The following is a description of a gene set: Human Gene Set: MIR6892_3P studied in species Homo sapiens Genes predicted to be targets of miRBase v22 microRNA hsa-miR-6892-3p in miRDB v6.0 with MirTarget v4 prediction scores > 80 (high confidence targets). from publication Chen Y, Wang X (PMID 31504780), and this is the list of marker genes: ARRDC3, TRAF6, BCO2, SRSF6, SKAP2, ZBTB20, SSTR3, SYCP2, EMX2, TNS1, PTDSS1, LIN28B, MAFB, MSI2, CHD3, SLC39A1, ANAPC13, TMT1B, LYZL1, SDC3, DDX6, ASTN1, GLI3, RASSF2, SRP19, LMNTD1, SP8, ARHGAP25, SIX3, OR2H1, BCL9, AIF1L, CD2AP, ZDHHC17, JMY, C15orf32, NAPEPLD, RPF2, ADSS2, ZBTB12, TGFBR1, TRIM26, NR2F2, SAMD4B, C1orf174, FLCN, ARK2C, TMCC2, LYZL2, BCAS1, ABRAXAS2, PLOD1, RASL10B, ATXN7L3, SKP2, FAM241B (NCBI Gene Id 219738), FARP1, ATF7, PLPPR4, KRT77, NQO1, S1PR3, COA1, TRPM8, CBX6, SLITRK6 (SLIT and NTRK like family member 6), TNFRSF13B, TRMT2A, CREB3L4, NSL1, RCAN1, SEC61A1, SYT11, RNF44, CAMK2A, C2orf72, MECP2, MICAL3, PCNP, NLRC3, KLHL25 (NCBI Gene Id 64410), TMEM164, IER5, TREM1, PIK3R1, ID4, PPARGC1A, FAM171B, FAM193A, BPNT2, KCNQ2, BACE1, NXPH1, IFT46, ACSM2B, CPEB3, MBNL3, CAPS2, ARHGAP10, RNF212B, PATJ, TBC1D1, LUZP1